Given this list of marker genes DIO1, DUOXA1, SLC5A5, DIO2, CAV1, DUOXA2, IYD, DIO3, TXNDC11, TPO, CGA, DUOX2, DUOX1, TSHB, here is a description of the gene set: part of: Metabolism of amine-derived hormones Reactome Pathway: Thyroxine biosynthesis Production and secretion of the thyroid hormone T3 (3,5,3'-triiodothyronine) and its inactive precursor T4 (3,5,3',5'-tetraiodothyronine) by thyroid follicular cells is triggered by Thyroid-stimulating hormone (TSH, thyrotropin). T3 and T4 is taken up by target cells where more T3 is produced by deiodinating T4. Ultimately T3 binds to thyroid hormone receptors in the nucleus and regulates the target cell's gene expression. In the thyroid, follicular cells form a compartment that traps iodide imported from the blood plasma. T3/T4 synthesis proceeds on thyroglobulin (TG) as a platform; each monomer provides about 30 tyrosine (Tyr) residues for iodination. TG carrying the iodinated Tyr residues is then imported into follicular cells and cleaved in lysosomes, releasing T3, T4 and other iodinated tyrosines. Released iodide is recycled. Finally T3 and T4 are exported to the blood. species: Homo sapiens